The following is a description of a gene set: Any process that activates or increases the frequency, rate or extent of blood vessel endothelial cell proliferation involved in sprouting angiogenesis. Human Gene Set: GOBP_POSITIVE_REGULATION_OF_BLOOD_VESSEL_ENDOTHELIAL_CELL_PROLIFERATION_INVOLVED_IN_SPROUTING_ANGIOGENESIS species: Homo sapiens, and this is the list of marker genes: HMOX1, MIR503, MIR132, PPP1R16B, MIR10A, APELA, MIR487B, MIR21, MIR23A, MIRLET7B, APLNR, VEGFA, AGTR1, FGFBP1, MIR10B, JCAD, NUS1, MIR101-1, MIR27B, MIR146A, MIR126, MIR27A, GATA2